The following is a description of a gene set: Human Gene Set: GOBP_RECOMBINATIONAL_REPAIR species: Homo sapiens A DNA repair process that involves the exchange, reciprocal or nonreciprocal, of genetic material between the broken DNA molecule and a homologous DNA region., and this is the list of marker genes: YY1, RAD21, XRCC2, NSMCE1, RAD50, NSMCE4A, PELI1 (NCBI Gene Id 57334), ZSWIM7, TIMELESS, MAGEF1, RMI2, PALB2, PIAS4, MRE11, MORF4L2, RTEL1, NUCKS1, RAD54L, TONSL (NCBI Gene Id 4796), INTS3, RNF138, ING3, CHD4, HELB, MMS22L, MCM4, KAT5, NSMCE3, TOP3A, UBQLN4, ANKLE1, PARPBP, NSMCE2, TEX15, PLK1, MCM6, REC8, ACTL6A, MCM5, WDR48, POLL, MCM3, HUS1B, HUS1, KLHL15, SWSAP1, POLN, DMAP1, SFR1, SHLD3, RAD54B, AP5S1, EID3, FIGNL1, PPP4R2, SLX1A, RAD52, MORF4L1, CDC7, ZNF365 (NCBI Gene Id 89878), NABP2, RAD51B, TRRAP, FBH1, ACTB, PARP1, CREBBP, SFPQ, BRCA1, RAD51C, SHLD1, MEAF6, CSNK2A1, NIPBL, RNF126, PPP4C, XRCC5, BRCA2, SKP2, ACTR2, RPA4, RUVBL2, SLF1, SMC6, ZGRF1, SMCHD1, GINS4, CDC45, SENP3, TP53BP1, CTBP1-DT, HELQ, VPS72, DMC1, POGZ, FANCB, SPIDR, RHNO1, INIP, MAD2L2, RPA2, FANCM, SEM1, ERCC6, YEATS4, ASTE1, UHRF1, EP400, XRCC6, RMI1, RNF169, C1QBP, RIF1, MRNIP, ABL1, PRMT1, HDGFL2, WRAP53, EPC1, SLX4, FAN1, WAS, RADX, HTATSF1, MCM8, WRN, EPC2, MEIOB, CHEK1, USP51 (NCBI Gene Id 373510), ZFYVE26, ATM, KMT5A, ARID2 (AT-rich interaction domain 2), KDM4D, ERCC4, MRGBP, AP5Z1, H2AX, RBBP8, RUVBL1, RPA1, SAMHD1, SLF2, EXD2, GEN1, MCMDC2, BLM, RECQL4, REV3L, XRCC3, KASH5, RAD51D, SMC5, ERCC5, MCM9, UBE2N, RAD51AP1, KHDC3L, AUNIP, OOEP, NBN, RPA3, CGAS, SETD2, INO80, NABP1, MUS81, PSMD14, GINS2, FEN1, MBTD1, SWI5, RECQL5, TOPBP1, SHLD2, RAD51, SLX1B, TERF2IP, MCM2, RAD21L1, MCM7 (minichromosome maintenance complex component 7), FUS, RECQL, RNF8, LIG3, RFWD3, POLQ, SIRT6, KDM1A, BRD8 (NCBI Gene Id 10902), HROB, ZMYND8